Given this list of marker genes SORD, TPI1, GK2, TKFC, GPD2, GK, GK5, here is a description of the gene set: studied in species Homo sapiens The chemical reactions and pathways resulting in the breakdown of alditols, any polyhydric alcohol derived from the acyclic form of a monosaccharide by reduction of its aldehyde or keto group to an alcoholic group. Human Gene Set: GOBP_ALDITOL_CATABOLIC_PROCESS